The following is a description of a gene set: studied in species Homo sapiens Human Gene Set: ZNF433_TARGET_GENES from publication Yevshin I, Sharipov R, Kolmykov S, Kondrakhin Y, Kolpakov F (PMID 30445619) Genes containing one or more binding sites for (ZNF433) in their promoter regions (TSS -1000,+100 bp) as identified by GTRD version 20.06 ChIP-seq harmonization., and this is the list of marker genes: RRN3P1, GXYLT2, SDC4, ACER3, MTFMT, FES, MTND1P14, CYP1B1-AS1, DAGLB, NOL6, QSER1, GALNTL5, HEBP2, TTC1, COPS3, ASS1P5, FRMD7, GIT2, ENSG00000265246, KAT8, FMN2, BBLNP1, STX4, RPL36, CMKLR2-AS, NUCB1-AS1, RORA, OR1X5P, ITGAL-AS1, FCHO2, ZNF675, CCDC65, CROCCP3, TRIM15, RND1, SNHG30, RNU6-1003P (NCBI Gene Id 106481778), SPATS2L, DHTKD1, LINC01641, AP1S3, RPL32P27, GLG1, ANGPTL6, TNFRSF12A, SLC6A1, ALDOA, TRAV15, TTLL13, TMEM98, HAPLN2, BORCS6, WNT8A, LINC01235, MTO1, COQ10A, C6orf141, EXOSC2, NLE1, MED21, RNU6-166P, CWC25, AURKB, FABP5P3, LUZP1, SYCE2, RN7SL93P, SH2B3, TNFRSF10B